Given this list of marker genes COLEC10, TRPV4 (NCBI Gene Id 8098), DCHS1, COLEC11, MASP1, SH3PXD2B, FAT4, TAF1, TBX15, here is a description of the gene set: Human Gene Set: HP_ABNORMAL_COCCYX_MORPHOLOGY studied in species Homo sapiens Abnormal coccyx morphology Any structural abnormality of the coccyx.